Given this list of marker genes CD70, CTPS1, TCF3, RIPK1, SEC61A1, REL, CBLB, here is a description of the gene set: Partial absence of specific antibody response to tetanus vaccine Human Gene Set: HP_PARTIAL_ABSENCE_OF_SPECIFIC_ANTIBODY_RESPONSE_TO_TETANUS_VACCINE species: Homo sapiens A reduced ability to synthesize postvaccination antibodies against a tetanus antigen, as measured by antibody titer determination following vaccination.